Given this list of marker genes TP53, CDK6, CCND2, E2F2, MDM2, E2F1, RB1, E2F3, CDKN2A, CDKN1A, CDK4, CCND1, CCND3, here is a description of the gene set: Pathway Definition from KEGG: CDKN2A -| MDM2 -| TP53 => CDKN1A -| (CCND+CDK4/6) -> RB1 // E2F studied in species Homo sapiens Human Gene Set: KEGG_MEDICUS_REFERENCE_MDM2_P21_CELL_CYCLE_G1_S_N00066 MDM2-p21-Cell cycle G1/S. Pathway ID: N00066. Pathway type: Reference. Pathway class: nt06263 Hepatocellular carcinoma.